The following is a description of a gene set: mouse primary BMDCs were stimulated with tlr ligands and gene expression changes were profiled on Affymetrix arrays from publication Amit I, Garber M, Chevrier N, Leite AP, Donner Y, Eisenhaure T, Guttman M, Grenier JK, Li W, Zuk O, Schubert LA, Birditt B, Shay T, Goren A, Zhang X, Smith Z, Deering R, McDonald RC, Cabili M, Bernstein BE, Rinn JL, Meissner A, Root DE, Hacohen N, Regev A (PMID 19729616) species: Homo sapiens Human Gene Set: GSE17721_LPS_VS_GARDIQUIMOD_6H_BMDC_UP Genes up-regulated in comparison of dendritic cells (DC) stimulated with LPS (TLR4 agonist) at 6 h versus DC cells stimulated with Gardiquimod (TLR7 agonist) at 6 h., and this is the list of marker genes: VWA5A, GADD45B, BLNK, NCOA1, ANKS1A, TMEM219, PLCL2, ZBTB7A, SPMAP2, ZFX, TBK1, CCL4, GSTO1, SLC28A2, PLEKHA2, REEP3, CD83, UBTF (NCBI Gene Id 7343), SPG7, PARP14 (poly(ADP-ribose) polymerase family member 14), C1orf35, MAGED1, STXBP1, SLIRP, RAB12, RUNX3, SEC22A, SETD7, CEP19, NAA20, FABP4, RELL1, DCBLD2, RAB22A, STX3, INMT, SAMHD1, GATAD2A, EVA1A, NSMAF, NXF1, PURA, BTRC, RGS1, AGER (NCBI Gene Id 177), VRK2, CYP24A1, DNAJC13, STRA6, ASTN1, IST1, CSNK1A1, CHD4, OR2S2, FNDC3A, PLK2, MTOR, COPS2, APMAP, PITPNC1, ICAM1, FSCN1, TMOD3, DOK1, HOXC4, KREMEN1, SHFL, ATP11B, SLF1, CPNE3, JUND, POMC, CASK, ITGAV, DRC1, RRAS2, HLA-B, WNK1, B4GALT4, CALCR, ADCY3 (adenylate cyclase 3), CPT1A, RAB9A, HELZ2, SECISBP2L, MYD88, FOXP1, ST6GALNAC4, DEK, NTF3 (NCBI Gene Id 4908), NOC4L, BRI3, RND3, TAB2, CHTOP, CBFA2T2, KITLG, MXI1, UPF2, MACROH2A1, ARCN1 (NCBI Gene Id 372), TBC1D1, COQ3, CHRNE, SLC6A4, HMGCS2, DR1, SOS1, KCNMA1 (potassium calcium-activated channel subfamily M alpha 1), IL21R, STARD3NL, ASF1A, MYBPH, STX5, GNPDA2, KATNA1, HINFP, KLK11, ADAP2, RGCC, BCKDHB, DTD1, ATAD1, RNF135, LRAT, LANCL2, FOXO1, ARL4A, TOX4, GTPBP2, ITIH3, MTHFR, LHB, TCF20, CAMLG, NAT1, NOTCH2, UBE2W, TANC1, ZNF3, AIDA, PTPN6, POP4, FAM3B, MED28, LYPD8, FHOD3, PRG3, NAP1L2, STAM2, SEH1L, NMNAT1, TMEM50B, GHITM, RAB30, PNRC1, NES, FMR1, FKBP9, ZBP1, DNAJB11, SUB1, NAA80, ENG, IL1RAP, MX2, PPIF, IFIT3, SFT2D2, GBP6, PBX3, TLCD2, MPRIP (myosin phosphatase Rho interacting protein), SSBP3, PIM1, UBE2D1, WASF3, MSI1, CD164, TFG, EPAS1, ANK3, ABHD16A, LCK, SH2D2A, SNX2, NRBP1, PDGFRB, IFNAR2, RHOH (NCBI Gene Id 399), CRBN, BAIAP2, TMTC4, AKR1B1, MAD2L1, FBXO25, SLC16A2, PSME4, UBA7, TSPYL1